The following is a description of a gene set: Human Gene Set: GOBP_POSITIVE_REGULATION_OF_HIPPO_SIGNALING Any process that activates or increases the frequency, rate or extent of hippo signaling. studied in species Homo sapiens, and this is the list of marker genes: STK4, TIAL1, DLG5, FRMD6, STK3, SCHIP1, AARS1, PRP4K, MAP4K4, FRMD1, ARRDC3, CORO7, IQCJ-SCHIP1, YWHAE, SOX11